The following is a description of a gene set: from publication Wang Z, Zang C, Cui K, Schones DE, Barski A, Peng W, Zhao K (PMID 19698979) Histone acetyltransferases (HATs) and deacetylases (HDACs) function antagonistically to control histone acetylation. As acetylation is a histone mark for active transcription, HATs have been associated with active and HDACs with inactive genes. We describe here genome-wide mapping of HATs and HDACs binding on chromatin and ﬁnd that both are found at active genes with acetylated histones. Our data provide evidence that HATs and HDACs are both targeted to transcribed regions of active genes by phosphorylated RNA Pol II. Furthermore, the majority of HDACs in the human genome function to reset chromatin by removing acetylation at active genes. Inactive genes that are primed by MLL-mediated histone H3K4 methylation are subject to a dynamic cycle of acetylation and deacetylation by transient HAT/HDAC binding, preventing Pol II from binding to these genes but poising them for future activation. Silent genes without any H3K4 methylation signal show no evidence of being bound by HDACs. Human Gene Set: GSE15735_CTRL_VS_HDAC_INHIBITOR_TREATED_CD4_TCELL_2H_DN Genes down-regulated in CD4 T cells: control versus treated with HDAC inhibitors for 2h. studied in species Homo sapiens, and this is the list of marker genes: THY1, VARS1, EOMES, RAB19, TRMT112, CXXC5, EXOC4, METTL1, CENPV, POLR1B, KIF14, DMRTA1, DOCK10, IGF2BP2, AXDND1, CDC42BPG, BEND4, RSAD1, TTYH1, MYRFL, PSME1, ZNF354C, P3H4, PUS7, PPIC, GZMM, CDC14B, HACD1, FBF1, CCR9 (C-C motif chemokine receptor 9), B3GNT5, CD8A, CD79B, SHMT2, ERCC1, WDR17, NKG7, SLC6A19, SLC35G1, ZNF2, LPXN, TM6SF1, CNR2, B4GALNT1, SLC11A2, SYTL3, PLEKHA6, NCKAP1, CHSY1, USP20, SLC16A6, PRF1, FGF13, CD72, GGT1, SLC25A53, GAB3, PIGP, SLC35E3, ABHD15, SFXN1 (NCBI Gene Id 94081), GJC2, FCGRT, COL23A1, DENND4C, MGAT4A, NCF1, STX2, NTN3, MCTP2 (multiple C2 and transmembrane domain containing 2), DEPDC1B (DEP domain containing 1B), STAT4, HDAC7, FAM241A, RHOQ, CCDC102A, SEMA4A, TMEM108, RCL1, C19orf38, PNPO, OXTR, XRN2, CST7, ART4, GLIPR2, SDR42E1, SLC16A1, WIF1, ACTN2, SCFD2, BICDL2, ATP8B4, PHGDH, SNAI3, ENTREP3, MRI1, TKT, BACE1, IER3, ENG, CTSC, RPL23A, EHD1, USP11, ZNF318, YDJC, TRMT10A, HLA-DMA, IQSEC1, GGA2 (golgi associated, gamma adaptin ear containing, ARF binding protein 2), DNAJC15, FRMD4A, SELPLG, TMEM160, MCOLN2, AGTR2, HLA-DOA, TOGARAM1, GATAD2A, PLAC8, HPCAL1, SLA2, IVD (NCBI Gene Id 3712), BAIAP3, CTSW, SIRT3, CRTAM, ADAM19, RECK, KLHDC7A, POGLUT2, KCNC3, SERPINA11, PIGA, TLR6, CLCF1, PTPN22, COX8A, DPP4, CD302, PARVG, RPS26, GAR1, PLEKHO1, ZYX (zyxin), ZNF600, DPCD, GOLM2 (golgi membrane protein 2), SNHG17, LYRM7 (LYR motif containing 7), SIAE, SIDT1, PDE2A, FLOT1, CAPRIN2, SERPINI1, CD8B, KLRD1, ADAM9, PLEK, AP3M2, CHRNB1, RCN3, IFITM10, GARIN3, EFCAB7, NBEAL2, B3GAT3, NLN, DIAPH3, TPD52L1, ELOVL7, TAGLN2, ILDR1 (immunoglobulin like domain containing receptor 1), ANXA6, RACGAP1 (Rac GTPase activating protein 1), SORL1, MEAK7, LRRC75B, GDAP1L1, SHFL, EPSTI1, SMAP2, PIM2, GPR68, APOBEC3B, MICAL1, ADGRG5, KLK8, G0S2, MYO7A, HAAO, SLC25A4, SMYD2, TENT5A, F2R, RRAS2, PEAK1, ITGAE